Given this list of marker genes CHD7, FKBP1A, ASPH, JPH4, ATP1A2, PDE4D, JPH1, DMD, HRC, TMEM38B, GSTO1, PRKACA, SLC8A1, TRDN, ANK2 (ankyrin 2), AKAP6, MIR133A1, TMEM38A, CLIC2, DHRS7C, CAMK2D, CACNA1C (NCBI Gene Id 775), JPH2, SRI, CALM1, MIR93, MIR1-1, RYR2, CASQ2, JPH3, FKBP1B, PLN, CASQ1 (calsequestrin 1), METTL21C (NCBI Gene Id 196541), GSTM2, CALM3, CALM2, here is a description of the gene set: Any process that modulates the rate, frequency or extent of release of sequestered calcium ion into cytosol by the sarcoplasmic reticulum, the process in which the release of sequestered calcium ion by sarcoplasmic reticulum into cytosol occurs via calcium release channels. Human Gene Set: GOBP_REGULATION_OF_RELEASE_OF_SEQUESTERED_CALCIUM_ION_INTO_CYTOSOL_BY_SARCOPLASMIC_RETICULUM species: Homo sapiens